Given this list of marker genes NOP16, ETFA, SSRP1, PSMD14, MRPL22, RRM1, SNRPA, XRCC5, SLBP, MCM7, EIF2S1, FH, PTGES3, CSE1L, MCM5, SF3B3, MRPL35 (mitochondrial ribosomal protein L35), GMNN, RANBP1, NDC80, SERBP1, MTHFD2 (NCBI Gene Id 10797), BANF1, PA2G4, CCT3, NUP37, MRPL15, FDPS, MLH1, RAN, NCL, IARS1, TARS1, TCP1, PCNA, ABCE1, MCM4, PSMD11, U2SURP, SNRPE, MRPL39, HNRNPA2B1, PAICS, PSMA4, MCM3, SNRPD1, SSBP1, BUB3, CLNS1A, NUP107 (NCBI Gene Id 57122), PSMA3, HAT1, CENPM, CDK4, LSM5, CAD (NCBI Gene Id 790), CCT2, NAE1, MRPL3, LRPPRC, CHCHD3, LSM4, MRPL16, H2AZ1, SNRPB, CCT4, MELK (NCBI Gene Id 9833), NASP, SNRPG, MCUR1, CKS1B, BUB1B, METTL5, DKC1, CCT6A, GMPS, NDUFS1, CCT5, OLA1, here is a description of the gene set: Neighborhood of PA2G4 proliferation-associated 2G4, 38kDa in the GNF2 expression compendium studied in species Homo sapiens Human Gene Set: GNF2_PA2G4 Neighborhood of PA2G4